The following is a description of a gene set: Any process that stops, prevents, or reduces the frequency, rate or extent of the Notch signaling pathway. studied in species Mus musculus Mouse Gene Set: GOBP_NEGATIVE_REGULATION_OF_NOTCH_SIGNALING_PATHWAY, and this is the list of marker genes: Hey1, Arrb1, Dll4, Hif1an, Lrrk2 (leucine-rich repeat kinase 2), Slc35c1, Rfng (NCBI Gene Id 19719), Dll1, Nfkbia, Nrarp, Gdpd5, Neurl1a, Tcim, Ovol2, Bcl6, Notch4, Zbtb7a, Dlx1, Chac1, Egfl7, Ccnc, Arrdc1, Lfng, Rita1, Dlk2, Gata2, Cbfa2t2, Dlk1, Herc2, Bmp7, Kctd10, Mmp14, Rian, Tspan15, Dlx2, Ythdf2, Bend6, Cdk3, Mettl3 (NCBI Gene Id 80554), Hey2, Dll3